The following is a description of a gene set: studied in species Homo sapiens Genes predicted to be targets of miRBase v22 microRNA hsa-miR-4765 in miRDB v6.0 with MirTarget v4 prediction scores > 80 (high confidence targets). from publication Chen Y, Wang X (PMID 31504780) Human Gene Set: MIR4765, and this is the list of marker genes: FAM72A, CYP7B1, SNX6, DIS3, ZNF346, AIF1L, FAM72B, PRKAR1A, CCSER1, TTLL2, STS, WDFY3, ELN, MEGF11, RFX3, C1QL3, KCNJ6, SLC1A6, ZZZ3, ESYT3, PYROXD1, VNN2, HOMER1, ITGA8, ANKH, CNR1, TEC (tec protein tyrosine kinase), FOXP1, FAM72C, GPATCH2, GSG1L, HNRNPR, TCF3, CLTRN, PTGIS, SOX6, PHKA1, KDM4C (lysine demethylase 4C), ACAT1, TMPRSS11D, STRN, ZNF239, FOXK2, CCDC28A-AS1, SGCG, LIN28B, PHIP, FAM72D, POPDC2, SFRP1, KALRN, TTC17